The following is a description of a gene set: Human Gene Set: GOBP_C_X_C_CHEMOKINE_RECEPTOR_CXCR4_SIGNALING_PATHWAY The series of molecular signals initiated by a the C-X-C chemokine type 4 receptor on the surface of a cell binding to one of it's physiological ligands, and ending with the regulation of a downstream cellular process, e.g. transcription. species: Homo sapiens, and this is the list of marker genes: LYN, TREM2, CXCR4, WBP1L, CXCL12, ENTREP1